Given this list of marker genes Mapk13, Atg7, Hnrnpa1, Daxx, Hsf1, Zc3h12a, here is a description of the gene set: species: Mus musculus Any process that results in a change in state or activity of a cell (in terms of movement, secretion, enzyme production, gene expression, etc.) as a result of a sodium arsenite stimulus. Mouse Gene Set: GOBP_CELLULAR_RESPONSE_TO_SODIUM_ARSENITE